The following is a description of a gene set: Any process that modulates the rate, frequency or extent of cardiac epithelial to mesenchymal transition, a transition where a cardiac epithelial cell loses apical/basolateral polarity, severs intercellular adhesive junctions, degrades basement membrane components and becomes a migratory mesenchymal cell. species: Mus musculus Mouse Gene Set: GOBP_REGULATION_OF_CARDIAC_EPITHELIAL_TO_MESENCHYMAL_TRANSITION, and this is the list of marker genes: Tgfb2, Jag1, Tgfbr1, Tgfb1, Emp2 (NCBI Gene Id 223964), Eng (endoglin), Notch1, Tgfb3, Nog, Twist1, Tgfbr2, Acvr1